The following is a description of a gene set: Human Gene Set: WP_PERTURBATIONS_TO_HOSTCELL_AUTOPHAGY_INDUCED_BY_SARSCOV2_PROTEINS species: Homo sapiens Perturbations to host-cell autophagy, induced by SARS-CoV-2 proteins, and this is the list of marker genes: ULK1, NBR1, GABARAPL2, PRKAA2, RPTOR, ATG4A, VAMP8, ATG5, LARP1 (La ribonucleoprotein 1, translational regulator), ATG12, VPS41, VPS18, AKT1S1, VPS11, PPP1R9A, LAMP2, RPS6KB1, AKT1, CALCOCO2, VPS39, TAX1BP1, ATG3 (NCBI Gene Id 64422), APOB, MAP1LC3B, RHEB, ATG9A, SQSTM1, RPS6, ATG2B, DEPTOR, VPS33A, ATG16L1, RAB7A, VPS16 (NCBI Gene Id 64601), OPTN, LAMTOR1, PKM, TMEM59, EIF4B, RB1CC1, ATG13, ATG7, MLST8, MTOR